The following is a description of a gene set: Mouse Gene Set: GOMF_POTASSIUM_CHANNEL_REGULATOR_ACTIVITY species: Mus musculus Binds to and modulates the activity of a potassium channel., and this is the list of marker genes: Dpp6, Kcne1, Wnk2, Sgk1, Amigo1 (adhesion molecule with Ig like domain 1), Lrrc55, Kcns3, Kcng2, Kcnv1, Sgk2, Kcne3, Prkcz, Kcnab3 (NCBI Gene Id 319671), Kcnip2, Fxyd5, Lrrc38, Kcnb2, Wnk1, Abcc9, Kcnip1, Kcng3, Wnk4, Pias3, Dpp10, Lrg1, Sgk3, Kcng4, Ank2, Kcns1, Flna, Kcnip3, Cav1, Cav3, Ensa, Wnk3, Dlg1, Kcne2, Akap9, Lrrc52, Kcne4, Kcnmb4, Ywhae, Kcnb1, Kcnab1, Akt1, Kcnmb2, Kcng1, Kcnmb3, Kcnv2, Arpp19, Kcnf1, Adrb2, Kcnip4, Kcnmb1, Kcne5, Nedd4l, Kcns2, Kcnab2, Slc5a3, Sumo1, Kcnk2 (NCBI Gene Id 98453), Lrrc26